Given this list of marker genes Pdpn, Enpp2, Coro1c, Arpin, Kank1, Src, Coro1b, Vil1, Rreb1, Cd44, here is a description of the gene set: Any process that modulates the frequency, rate or extent of lamellipodium morphogenesis. studied in species Mus musculus Mouse Gene Set: GOBP_REGULATION_OF_LAMELLIPODIUM_MORPHOGENESIS